Given this list of marker genes NAGA, GLA, GLB1L3 (galactosidase beta 1 like 3), GLB1, GLB1L2, GBA3, GLB1L, here is a description of the gene set: Human Gene Set: GOMF_GALACTOSIDASE_ACTIVITY Catalysis of the hydrolysis of galactosyl compounds, substances containing a group derived from a cyclic form of galactose or a galactose derivative. studied in species Homo sapiens